The following is a description of a gene set: Mouse Gene Set: GOMF_CD4_RECEPTOR_BINDING studied in species Mus musculus Binding to a CD4, a receptor found on the surface of T cells, monocytes and macrophages., and this is the list of marker genes: Plscr2, H2-Eb1, Lck, Il16, Plscr4, Fyn, Cd22, H2-Eb2, Cd74, Spg21, Plscr1